Given this list of marker genes GLYATL3, GLYATL2, GLYATL1, ACSM2B, ACSM1, GLYAT, here is a description of the gene set: studied in species Homo sapiens Human Gene Set: REACTOME_CONJUGATION_OF_BENZOATE_WITH_GLYCINE Conjugation of benzoate with glycine